The following is a description of a gene set: from publication Samols MA, Skalsky RL, Maldonado AM, Riva A, Lopez MC, Baker HV, Renne R (PMID 17500590) Genes up-regulated in 293 cells (embryonic kidney) upon expression of KHSV (Kaposi sarcoma-associated herpesvirus) microRNAs. MicroRNAs (miRNAs) are 19 to 23 nucleotide-long RNAs that post-transcriptionally regulate gene expression. Human cells express several hundred miRNAs which regulate important biological pathways such as development, proliferation, and apoptosis. Recently, 12 miRNA genes have been identified within the genome of Kaposi sarcoma-associated herpesvirus; however, their functions are still unknown. To identify host cellular genes that may be targeted by these novel viral regulators, we performed gene expression profiling in cells stably expressing KSHV-encoded miRNAs. Data analysis revealed a set of genes whose expression was significantly changed in the presence of miRNAs. While the majority of changes were below 2-fold, eight genes were down-regulated between 4- and 20-fold. We confirmed miRNA-dependent regulation for three of these genes and found that protein levels of thrombospondin 1 (THBS1) were decreased >10-fold. THBS1 has previously been reported to be down-regulated in Kaposi sarcoma lesions and has known activity as a strong tumor suppressor and anti-angiogenic factor, exerting its anti-angiogenic effect in part by activating the latent form of TGF-beta. We show that reduced THBS1 expression in the presence of viral miRNAs translates into decreased TGF-beta activity. These data suggest that KSHV-encoded miRNAs may contribute directly to pathogenesis by down-regulation of THBS1, a major regulator of cell adhesion, migration, and angiogenesis. Human Gene Set: SAMOLS_TARGETS_OF_KHSV_MIRNAS_UP species: Homo sapiens, and this is the list of marker genes: GALNT3, AK3, ZNF93, SLC31A1 (solute carrier family 31 member 1), CDH11, SOX11, COCH, GAL